Given this list of marker genes SDC1, SSPN, MYBL2, FGFR2 (NCBI Gene Id 2263), KRAS, MET, MYC, here is a description of the gene set: Array-based comparative genomic hybridization (CGH-array) has a powerful potential for high-throughput identification of genetic aberrations in cell genomes. We identified a homozygous loss of ADAM23 (2q33.3) in the course of a program to screen a panel of gastric cancer (GC) cell lines (1/32, 3.1%) for genomic copy-number aberrations using our custom-made CGH-array. Infrequent homozygous deletion of ADAM23 was also seen in primary gastric tumors (1/39, 2.6%). ADAM23 mRNA was expressed in normal stomach tissue, but not in the majority of GC cell lines without homozygous deletion of this gene. Expression of ADAM23 mRNA was restored to gene-silenced GC cells after treatment with 5-aza 2'-deoxycytidine. The methylation status of the ADAM23 CpG island, which showed promoter activity, correlated inversely with its expression. Methylation of this CpG island was observed both in GC cell lines and in primary GC tissues; in primary tumors with a hypermethylated CpG island, expression of ADAM23 was lower than in adjacent noncancerous tissues. Moreover, restoration of ADAM23 in GC cells reduced their numbers in colony-formation assays. These results suggest that genetic or epigenetic silencing by hypermethylation of the ADAM23 CpG-rich promoter region leads to loss of ADAM23 function, which may be a factor in gastric carcinogenesis. Candidate genes in the regions of copy number gain in gastric cancer cell lines. from publication Takada H, Imoto I, Tsuda H, Nakanishi Y, Ichikura T, Mochizuki H, Mitsufuji S, Hosoda F, Hirohashi S, Ohki M, Inazawa J (PMID 16103878) Human Gene Set: TAKADA_GASTRIC_CANCER_COPY_NUMBER_UP species: Homo sapiens